Given this list of marker genes LPCAT1, GNG11 (NCBI Gene Id 2791), TFAP2A, NPC1, PSMD7 (NCBI Gene Id 5713), PDXK, STAM, HNRNPA1, CRABP2, NME1, ANP32B, DNAJB1, LCN2, PALM2AKAP2, CD59, ANXA2P1, GM2A, PSMA4, NRDC, RPS15A, CYP3A5, MRPS12, CDK2AP2, PTTG1IP (NCBI Gene Id 756), FBP1, GPI, HSPA1A, RPS6KB1, KLF9, CLU, LGALS7, SLC25A46, CDC25B, MRPL28, UBE2C, MYL9, IL1B, CTSK, KRT5, LY6E, PLK2, PLEC, PTGDS, PTTG1, FARSA, CTCF, IGFBP7, KRT16, PRPF6, EMP2, SLC20A1, SETD3, DPM2, PCBP1, GATA3, SLC16A3, AKR1C1, XRCC5, SELENBP1, LMTK2, SPINK1, ACTR2 (NCBI Gene Id 10097), PFKL, KRT14, TM4SF1, MICB, LGALS3BP, SLC2A3, MMP15, SERPINE2, PI3, AP2A2, SRGAP3, MAP1LC3B, KRT7, IFI27, PCNA, PNP, NDUFS8, DHRS2, FADS1 (fatty acid desaturase 1), IL1RN, TNIP1, MAGED2, MYL12A (NCBI Gene Id 10627), EPOR, IFITM1, LAMA3, CEACAM6, TUBB2A, DPF2, DST, S100P, SAA1, ADGRG1, CYP1B1, VIM, HSPA4, TUBBP1, PTX3, HMOX1, FN1, VCL, FASTK, LAMB1, ASAH1, CKS2, CRIP2, TFAP2C, CFLAR, S100A8, KRT18, CDKN1A, TRIM37, ALAS1, MAOA, RRAD, KRT8, BLCAP, RARS1 (NCBI Gene Id 84715), TMEM106C, ELOVL5, LUM, ISG20, CDK4, RASA1, COL1A2, ANXA2, CTSD, AURKA, BRD2, SFRP1, BHLHE40, FEN1, TUBG1, GRN, GRIP2, GFUS, SEMA3F, DAXX, EZH2, EIF4E2, SMARCA2, AP1G2, ATP6V0D1, MRPL49, SERPINB5, BTG1, BAIAP2, MBOAT7, NXF1, ZNF217, TGM2, NUPR1, SH2B3 (SH2B adaptor protein 3), SPARC, LAMA5, HSPA6, KLHL9, FHL2 (four and a half LIM domains 2), CTNNAL1, TPX2, SERPING1, UBE2M, TSC22D3, MSN, TNFAIP6, AURKB, EPCAM, ZFP36L2, TXNRD1, SERPINB2, ADGRG6, SERBP1, STAT6, PSMD5, UBC, AGR2, RAC3, CRYAB, LITAF, CCL2, APRT, TIMP3, FGFBP1, PCLAF, SFN, FAP, MT1X, PCCB, MYC, TPM1, TGFBI, ERCC1, SERPINE1, MDK, HSPE1, NFATC3, EEF1A2, PPID, DHRS3, MMP1, TMEM47, COX7A1, JUP, CLIC4, ATP5F1D, IGKV1OR1-1, PURA, EEF1D, MUC1, CREB3L2, BICD2, LIMK2, ACTA2, ANXA3, GSTP1, TRIO (NCBI Gene Id 7204), PALLD, CCND2, STIP1, GAGE13, TUBA4A, KTN1, COL17A1, ISG15, S100A10, LTA4H, ME1, APEX1, SERPINB4, SRSF6, CLDN7, PPM1E, TRIP6, AHNAK2, RBM4 (NCBI Gene Id 5936), ANXA1, TFF1, CRIM1, SNRPN, SOX15, ANKRD12, EIF3B, PPIB, COMMD4, CA12, KRT15, DTX2P1-UPK3BP1-PMS2P11, KRT6A, EBP (EBP cholestenol delta-isomerase), TFF3, XBP1, IFITM2, ITPR3, NNMT, LAMC2, CEBPB, PPL, S100A9, MT1A, TMEM158, TARDBP, EFNA3, VPS72, ACBD3, CLDN3, ARID5B, KRT81, PUF60, FLOT1, IRF6, CDH1, BASP1, LDHB, GOSR1, PEA15, S100A7, DDR1, IL6, SRGN, DAB2, KRT17, MCL1, TM7SF2, AXL, NHERF1, SERPINB3, FADS2, NINJ1, MCM7, E2F4, PRSS23, PTHLH, ASNS, SMAD3, OTUB1 (NCBI Gene Id 55611), CCND1, GSTO1, LY6G6C, CXCL8, ATP2A3, NDUFV1, H3P37, IDI1, POR, CAV1, SAT1, KRT19, SLC7A5, HSPB1, MCM2, CD24, HSPD1, COL6A3, RGS2, PSMD10, PRPF40A, NF2, LASP1, GJA1, CLEC11A, DNAJA1, here is a description of the gene set: from publication Lei W, Rushton JJ, Davis LM, Liu F, Ness SA (PMID 15105423) species: Homo sapiens Human Gene Set: LEI_MYB_TARGETS Myb-regulated genes in MCF7 (breast cancer) and lung epithelial cell lines overexpressing MYBL2, MYBL1 or MYB. The A-Myb and c-Myb transcription factors share a highly conserved DNA-binding domain and activate the same promoters in reporter gene assays. However, the two proteins have distinct biological activities, and expressing them individually in human cells leads to the activation of distinct sets of endogenous genes, suggesting that each protein has a unique transcriptional specificity. Here, the structural and functional features of the Myb proteins were compared, using assays of endogenous gene expression to measure changes in specificity. When the Myb proteins were tested in different cell types, they activated unique and nearly nonoverlapping sets of genes in each cellular context. Deletion and domain swap experiments identified small, discreet positive and negative elements in A-Myb and c-Myb that were required for the regulation of specific genes, such as DHRS2, DSIPI, and mim-1. The results suggest that individual functional elements in the transcriptional activation domains are responsible for activating specific cellular genes in a context-specific manner. The results also have important implications for interpreting results from reporter gene assays, which fail to detect the differences in activity identified through endogenous gene assays, and fusion protein constructs that alter the transcriptional activation domains and the activities of the Myb proteins.